The following is a description of a gene set: Human Gene Set: GSE37416_0H_VS_24H_F_TULARENSIS_LVS_NEUTROPHIL_UP Genes up-regulated in comparison of control polymorphonuclear leukocytes (PMN) at 0 h versus PMN treated with F. tularensis vaccine at 24 h. from publication Schwartz JT, Bandyopadhyay S, Kobayashi SD, McCracken J, Whitney AR, Deleo FR, Allen LA (PMID 22986450) studied in species Homo sapiens We demonstrated recently that both constitutive and FAS-triggered apoptosis of human neutrophils are profoundly impaired by Francisella tularensis, but how this is achieved is largely unknown. To test the hypothesis that changes in neutrophil gene expression contribute to this phenotype, we used human oligonucleotide microarrays to identify differentially regulated genes in cells infected with F. tularensis strain LVS compared with uninfected controls. In order to examine the effect of F. tularensis on the neutrophil transcriptome, we performed microarray expression analysis on human neutrophils treated with F. tularensis subsp. holarctica live vaccine strain (LVS)., and this is the list of marker genes: AGO4, RPS6KA3, ADAR, G6PD, MID1IP1, TRAPPC12, TRAPPC1, HMGCR, WDR13, CYP4F2, WNK1, TSPO, GCNA, DSC2, XRN2, PLOD1, MTM1, STK17B, SF3B3 (splicing factor 3b subunit 3), TPM3, TST, ATP2A3, MIR646HG, MYO15B, MSRB2, CAMK1D, RNF149, ROPN1L, DPYD, RELL1, FAM117B, S100A11, IL6R, DNAJA1, KIF21B, DYNLL1, MAP3K1, ACTN4, USP32, CCPG1, ARPC2 (actin related protein 2/3 complex subunit 2), DEF8, ACP3, SOS2, EBPL, MAP2K6, FES, TMT1A, JUNB, AIF1, CRNKL1, MAPK14, CEP63, TMEM272, RNF44, MEGF6, CST7, ACTR2, LAMTOR4, H2BC9, SLC8B1, LST1, ATRX, MAP7, H3C1, TYROBP, UBE2E3, SCPEP1, FLOT2, INPP4A, SOAT1, BCLAF1, SELP, PABIR1, CSTA, OR52K3P, ADCY10P1, TOPORS, ABHD3, HIPK3, MPPE1, GOLPH3, SNX18, TRERF1, CFLAR, SLMAP, CX3CR1, PARVG, ARHGAP9, PSMD9, ZNF92, GIMAP2, YTHDC2, SCP2, RNASET2, ARHGAP1, APAF1, SPAG1, INTS3, PLIN3, CTBP2, KPNA2, SRSF11, RAB5IF, IFIT5, NDUFB3, ADD1, NRDC, NFAM1, HSP90AA1, TMEM30A, DUSP12, GCA, KAT2B, ANKRD50, CA4, PHKA2, LPCAT2, GAA, AOC3, CASP8, TMEM45B, NASP, VCL, MANSC1, IMPA2, PPP1CA, PPM1F, MPZL1, CEBPA, BICD2, YIPF1, MBOAT7, HCG4B, DENND1A, OAZ2, TMEM131L, C1orf56, THOC5, APBB1IP, PMF1, HTATIP2, WAS, SLF1, ACOX1, C14orf93, TUBGCP3, TBCB, MBOAT2, ANTXR2, PGLS, PADI4 (NCBI Gene Id 82795), KLF13, HSPA8, MFSD14B (NCBI Gene Id 84641), HHEX, LMO4, LILRB1, CFL1, CAMK2G, WDFY3, PSTPIP1 (proline-serine-threonine phosphatase interacting protein 1), FCGR2C, UTRN, NUDT5, PRCP, WLS, CHMP5, KCTD21, ERICH1, ZKSCAN4, RMI1, MCL1, R3HDM4, ARGLU1, CD46, UCP2 (uncoupling protein 2), RFLNB, ARB2A, CYP4F3, CSF2RB (colony stimulating factor 2 receptor subunit beta), CREB5, STK38, CZIB, PHF2, GNPTAB, SUOX, CAB39, ZNF200, KLF6, TBC1D14, ALDH9A1, PKN2, TBCC, CXorf38